Given this list of marker genes RAP2C, RPL13A, MOB2, RUNDC3A, DOCK8, CTNS, COQ8A, EIF4G3 (NCBI Gene Id 8672), NSUN4, GCOM1, BCL9, HECTD1, SLC39A11, AIP, ZNF764, EIF3E, SIN3A, SVIL, WNT5B, MCOLN3, TMOD3, TLR6, APBB2, SMAD2, MMS19, SPON1, PBX1, GBA2, CSNK1D, INTS12, CHFR, DHX16, TECTA, ERAP1, ZNF362, MYO6, PRICKLE1, TRIM69, PPCDC, AKIRIN2, SUCO, PRDX6, DAPP1, SLC25A29, MTFR1L, AQR, CSDE1, TNFRSF25, CBFA2T2, PAF1, PLAUR, CYB5RL, WAC, MPEG1, GTPBP2, SH3GL1, GATA4, HINFP, ACTN2, TOP1, QPRT, CFP, TBC1D8B, TRAPPC14 (trafficking protein particle complex subunit 14), FLT3LG, WDR13, TUBGCP3, TSTD1, ARGLU1, C14orf180, EML3, HS6ST1 (heparan sulfate 6-O-sulfotransferase 1), CHD7, GABRE, ZNF622 (NCBI Gene Id 90441), SERF2, AP1M2, PTPN23, FERMT2 (NCBI Gene Id 10979), RAB2A, TEP1, ZNF276, S100A11, FAM120B, WIPF1, SPO11 (SPO11 initiator of meiotic double strand breaks), GADD45B, GZMK, HIPK3, SEC16A, MYL11, GABRG2, HBB, METTL23, RICTOR, MINK1, NT5C3A, PGLYRP1, SESN3, SPIN1 (spindlin 1), TMUB2, THY1, DENND4B, MYL6B, CSNK2A1, SLC22A5, SEC31A, SLC4A3, SEMA4D, UBL5, PEA15, FAM91A1, HNRNPDL, USP34, IGFBP4, LIMD2, FBXO21, IL17RB, MTURN, PLPP3, HSPA2, NTRK3, HAS2, LNX1, MSX1, ITIH5, DRC1, HIVEP2 (HIVEP zinc finger 2), MAP3K11, NARF, DBNDD2, MCRIP1, TOX, ZNF18, AGRP, INTS13, NCK2, PPP2CA, IER5, ARF5, STAG2, TMEM192, BCL6, JCHAIN, BRAP, PIWIL1 (NCBI Gene Id 9271), ANKIB1, CA6, PEAR1, CATSPERG, CMTM6, PLAAT3, HBS1L, NFE2L2, HVCN1, SERINC1, ZFAND3, KDM5B, RPS6KA2, FBXO25, XIST (NCBI Gene Id 7503), IREB2, QRICH1, PIGO, SLC23A3, OR2S2, MYD88, RPL30, SECISBP2, CEP95, UQCRHL, ZXDC, GAK, AKT2, VPS9D1, PCSK7, SDF4, MAP4K5, KLK11, TTLL3, HOXA5, MBIP, DHX15, PYROXD1, KCNMA1, CEP70, PTBP3, TMEM135, TMUB1, UNC93B1, OPA3, STX17, PARD6G, VPS39, EVI2A, PRSS35, RIOK1, FST, GLRA1, CAPN1, here is a description of the gene set: species: Homo sapiens Human Gene Set: GSE14908_RESTING_VS_HDM_STIM_CD4_TCELL_NONATOPIC_PATIENT_UP from publication Bosco A, McKenna KL, Firth MJ, Sly PD, Holt PG (PMID 19414752) The aim of this study was to employ a systems-level analysis to elucidate gene expression networks operating in the CD4 T-cell responses which underpin human atopic disease. Genes up-regulated in CD4 T cells from non-atopic donors: resting versus stimulated with allergen (house dust mite).